The following is a description of a gene set: studied in species Homo sapiens Crosslinking of collagen fibrils Human Gene Set: REACTOME_CROSSLINKING_OF_COLLAGEN_FIBRILS, and this is the list of marker genes: LOXL2, COL4A4, LOX, COL1A1, COL1A2, LOXL1, COL4A3, BMP1, LOXL3, TLL1, COL4A1, COL4A6, COL4A5, PXDN, COL4A2, TLL2 (NCBI Gene Id 7093), PCOLCE (NCBI Gene Id 5118), LOXL4